Given this list of marker genes TP53, FCMR, TSPAN32, HEATR6, BACH2, ARHGAP25, NAALADL1, SPON2, ADGRE2, BLK, P2RY10, TXLNGY, CD5, HMGN3, DPEP2, COL19A1, SPPL2A, BLOC1S5, KCNA3, PDE2A, FCRL2, ZFHX2, NME1, IRF8, IGHM, TAP1, TRAF3IP3, HDAC9, PLAC8, TCF7, RAPGEF6 (Rap guanine nucleotide exchange factor 6), TMEM97, CMKLR1, COA7, IL1R2, FOXP1, HLA-DRB3, TASL, IL4R, CCDC186, NCOA3, BMX, CNR2, RAX2, ADAM28, ICOSLG, UTY, PTPRO, MX1 (NCBI Gene Id 4599), OAS1, KIAA0753, IL24, ZFP36L2, TTLL2, PTPN6, PORCN, TCL1A, UNC5D, G6PC3, CXCR4, BIN2, DEFA1, OSBPL10, RCSD1, PNRC1, FANCF, MECP2, RSAD2, CLDN15, PTCRA, VANGL1, SP110, ITGB7, PTX3, SMCHD1, BCL2, ROR1, PRMT3, FGR, AMD1, IGHG3, SHC2, ANKRD28 (ankyrin repeat domain 28), ALOX5, ADA2, FAM53B, FCRLA, RUBCNL, MARCHF1, DBP, PLGRKT, CDC25B, CACNG4, C3orf36, FCER2, XIRP1, SOX6, NTRK3, KCNQ5, TNFAIP2, USP2, FCRL1, NEK11, TXNIP, MAP3K11 (NCBI Gene Id 4296), BANK1, SEL1L, FCGR2B, ZNF395, SPINT2, FADS3, IL10RA, DIRAS2, SLC27A5, COL4A4, PRKCB (protein kinase C beta), MED12L, DGKD, CTSF, MED25, RABIF, PCSK4, ABCC5, COQ9, HSD17B11, TRDD3, PTPN12, CD200 (CD200 molecule), ATP2A3, CTLA4, GABBR1, SLC24A3, PALM2AKAP2, TP53I13, NACAD, MED29, CD24, HVCN1, TOR1B, here is a description of the gene set: Human Gene Set: MODULE_188 Genes in the cancer module 188. species: Homo sapiens